Given this list of marker genes Hdac9, Pnkd, Polr3d, Adgrl3, Unc5c, Gtf2e1, Csrp2, Pde4d, Neurl1b, Col4a1, here is a description of the gene set: from publication Chen Y, Wang X (PMID 31504780) Mouse Gene Set: MIR_339_3P Genes predicted to be targets of miRBase v22 microRNA mmu_miR_339_3p in miRDB v6.0 with MirTarget v4 prediction scores > 80 (high confidence targets). species: Mus musculus